The following is a description of a gene set: The chemical reactions and pathways involving any member of a large group of derivatives or analogs of porphyrin. Porphyrins consists of a ring of four pyrrole nuclei linked each to the next at their alpha positions through a methine group. species: Homo sapiens Human Gene Set: GOBP_PORPHYRIN_CONTAINING_COMPOUND_METABOLIC_PROCESS, and this is the list of marker genes: ALAD, ALAS1, ABCC2, SLC48A1, SLC25A38, IREB2, SLCO1B1, HMOX2, TMEM14B, IBA57, RSAD1, HMBS, PGRMC1, CPOX, FECH, BLVRA, PPOX, SLC25A39, FLVCR1, BDH2, BLVRB, CYP1A1, SUCLA2, CYP1A2 (NCBI Gene Id 1544), TMEM14DP, AMBP, TSPO, UGT1A1, UGT1A4, ABCB7, NFE2L1, TMEM14A, TMEM14C, SLCO1B3, UROD, ALAS2, SLC6A9, COX15, FXN, ABCC1, EIF2AK1, SRRD (SRR1 domain containing), SLC46A1, TMEM14EP, ABCB6, COX10, HPX, HMOX1 (heme oxygenase 1), SLC11A2, ABCB10, SPTA1, ATP5IF1, SLCO2B1, UROS (NCBI Gene Id 7390)